The following is a description of a gene set: Human Gene Set: GOBP_NEUTROPHIL_MEDIATED_CYTOTOXICITY The directed killing of a target cell by a neutrophil. species: Homo sapiens, and this is the list of marker genes: NLRP6, CTSG, F2 (coagulation factor II), PCYOX1L, DNASE1, CXCL6, DNASE1L3, F2RL1, TUSC2, SCNN1B, MYD88, POMC, ELANE, AZU1, TREM1, ARG1, DAO, NCF1